Given this list of marker genes PMS1, APTX, TDG, PCNA, MSH6, MSH2, MUTYH, MLH1, MSH3, MSH4, XPC, PMS2, MLH3, MSH5, here is a description of the gene set: species: Homo sapiens Binding to a double-stranded DNA region containing one or more mismatches. Human Gene Set: GOMF_MISMATCHED_DNA_BINDING